Given this list of marker genes CRY1, CREBRF, CLOCK, PER1, BMAL1, CRY2, LMO3, PHB1, PPP5C, here is a description of the gene set: Any process that modulates the frequency, rate or extent of nuclear receptor-mediated glucocorticoid signaling pathway. studied in species Homo sapiens Human Gene Set: GOBP_REGULATION_OF_NUCLEAR_RECEPTOR_MEDIATED_GLUCOCORTICOID_SIGNALING_PATHWAY